The following is a description of a gene set: species: Homo sapiens Human Gene Set: MIR624_5P from publication Chen Y, Wang X (PMID 31504780) Genes predicted to be targets of miRBase v22 microRNA hsa-miR-624-5p in miRDB v6.0 with MirTarget v4 prediction scores > 80 (high confidence targets)., and this is the list of marker genes: DTX4, AVPR1A, SH3KBP1, HSPA4, NXT2, WWTR1, ZNF699, DOCK11, STMP1, SEC22A, FRS2, CSNK1G3, FAM114A2, GRPEL2, CLOCK, TAOK1 (NCBI Gene Id 80214), PURB, NOTCH2, CCDC182, RALGAPA1, ZFHX3, MSI2, MTMR10, CDK6, DHX29, YTHDF3, STK26, GHR, SLC44A5, STK24, UGDH, RAF1, HMGXB4, RGL3, AKTIP, RAB10, KRIT1 (KRIT1 ankyrin repeat containing), SUSD6, FIBIN, BRPF1, ADCY6, PTGS2, LSM12, SPON1, CHST9 (NCBI Gene Id 83539), SOWAHC, ERGIC1, DCUN1D1, TBX5 (NCBI Gene Id 6910), COLEC12, TMED4, F3, SYT1, BICD2 (NCBI Gene Id 23299), RASA2, EPC1, SNX30, ZNF800, CTNNB1, UAP1, MAX, BICC1, NFKBIA, PHIP (NCBI Gene Id 83843), LCP1, STK38, TRPM7, IDI1, SOX13, S100A7A, HSF2, CELSR2, RAP1GDS1, HOXD3, GPR63, YES1, ILK, TFRC, TMEM183A, NUCKS1, ZNF407, TGFBR1, DOCK5, ANKS1A, SLC25A46, BBX (BBX high mobility group box domain containing), PDE10A, FAM200B, PTGER4, THAP5, NCOR1, SMARCA1, KLHL23, DLG3, PARD3, LMTK2, FOXP1, AKAP10, DZIP1, ARL4A, CHRDL1, MET, PIK3CB (NCBI Gene Id 5291), LDAH, OTUD4